The following is a description of a gene set: Genes having at least one occurrence of the motif KNNNKAGGGGNAA in the regions spanning 4 kb centered on their transcription starting sites. This matches the transcription factor binding site V$MZF1_02 (v7.4 TRANSFAC). Human Gene Set: MZF1_02 species: Homo sapiens, and this is the list of marker genes: FOXL2, PNKD, MIR22HG, KLF6, WRAP53, CCDC24, PTPRF, VAMP1, TFE3, SSTR3, MEIS2, SON, LIN28A, FAM117B, ZMYND8, FRMD6, CXCL14, LRRTM4 (leucine rich repeat transmembrane neuronal 4), TAB2, ARID1A, DNMT3A, GART, PPP1R12A, HR, PAFAH1B1, LHX4, PPP1R10, HOXB8, ROR1, TLX1, ENSA, TBCC, LHX9, UTP18, FAM117A, SLC6A12 (NCBI Gene Id 6539), NFIX, NTRK3, SLC25A12, GPR162, C1orf21, LRRC8A, EIF3K, ZNF462, UQCRH, RAP2C, PHLDB3, MAP4K1, STX16, ZEB1, KLF12, EHF, MMP1, H1-0, MSI2, TAOK2, PTCH1, PRRC2A, ELOC, RCOR2, AAMP, JAKMIP2, NLGN2, CBX6, NCOA6, REL, WBP4, MAML2, EWSR1, NF1, ZNF24, MLLT6, GDPD2, PARP8, ARMCX3, WDR81, EGR3, MRPS18B, GABRA3, C6orf62, HMBOX1, IGF1R, SYT7, LRRTM1 (NCBI Gene Id 347730), OTX1, TRERF1, YWHAE, EYA1, HIC2, CASKIN2, NLK, CGGBP1, RFX5, TCF7L2, POLD4, VAX1, BRSK1, CLDN6, STC2, OGA, ANKS1B, CDX1, PCF11, H3-3B, BCL11B, PRRG2, VASP, ORC4, FOXP1, PLPP3, ATP1A2, CLDN15, IGF2BP3, CHD2 (chromodomain helicase DNA binding protein 2), MRPL14, HMX1, USP54, KLK13, PTGR3, UBE2K, TGFB1, RUNX3, HOXA10, G3BP2, KMT2E, NKX2-1, INTS9, COLCA1, HBP1, NFATC4, TFDP2, HNRNPA2B1, ZBTB26, CYP1A1, TFAP2D, RASGRP2, EHBP1, CBX3, SUPT16H, TP53, SOX30, PAX2, THPO, EVA1B, CSDE1, PHF12 (PHD finger protein 12), EFNA1, UNC80, PIK3AP1, MLLT10, ELAVL2, LRCH4, NFYC, MECOM (MDS1 and EVI1 complex locus), ADAMTSL1, LRRC41, ELF4, CDK13, CHRDL1, MTA2, SLC4A2, HSD11B1, SERPINB2 (NCBI Gene Id 5055), FBXO24, TLE3, ZBTB9, SEMA3F, SLC22A17, HOXC4, ELAVL4, FEZF2, PTCHD1, ZNF644, CAMTA2, DHX40, BAIAP2L2, VAT1, HNF1A, NOL4, LHX6, TMEM88, PRDM10, HOXB7, BCL9L, NOS1, ATXN7L2, SSBP3, ARHGAP1, XPR1, NAGS, ZNF408, GRK5, CDK12, P4HA1, TCEAL7, PHYHIP, FGF5, PATL1, HNF1B, OXCT1, SP4, TNPO2, TMEM256, FYN, KCNS3, KCNIP2, SKIDA1, HOXC11, ZNF532, GGN, BAHD1, MED13, NEUROD2, PLAG1 (PLAG1 zinc finger), RHBDD3, PCBP4, GGNBP2, FBRS, TSEN54, LCOR, LYPLA2, CHCHD7, JADE2, GPC6, PTMA, UBE4B, OTUB1, SALL1, MRC2, XPO1, SEMA4C, GRIN2D, TPT1, IGF2BP1, ASXL1, ALDH4A1